The following is a description of a gene set: Genes predicted to be targets of miRBase v22 microRNA mmu_miR_758_3p in miRDB v6.0 with MirTarget v4 prediction scores > 80 (high confidence targets). species: Mus musculus from publication Chen Y, Wang X (PMID 31504780) Mouse Gene Set: MIR_758_3P, and this is the list of marker genes: Lin7a, Hepacam2, Zfhx3, Stk40, Zbtb7a, Tyro3, Tfrc, Bach2, Slc33a1, Rhou, Nopchap1, Ntn5, Ctss, Xrcc2, Pum2, Cyp7b1, Slc6a14, 9530068E07Rik, Hipk3, 2310022B05Rik, Cacng5, Eea1, Sun2, Zfp560, Inhbc, Fli1, Hnrnpu, Map2k1, Xirp2, Iws1, Gad2, Fyttd1, Trabd2b, Lrfn2, Dpp4, Zcchc9, Map7d2, Zfp503, Zfpm2, Elmo2, Eda2r, Unc5d, Gcnt1 (glucosaminyl (N-acetyl) transferase 1, core 2), Cbx2, Herc2, Trim39, Dusp11, Txndc17, Cep15, Zbtb18, Abca1, Capn12, Meis2 (Meis homeobox 2), Cnnm4, Hsd11b1, Zfp618, Fbn1, 1600012H06Rik (NCBI Gene Id 67912), Gria4, Polr3f, Nsa2, Cadm2 (NCBI Gene Id 72986), Sestd1, Rad52, Tbx4, Tube1, Hlf, Mindy3, Ino80d, Ahcy, Pak5, Prkar2b, Rnls, Gpr174, Pgrmc1, Tbxas1, Bicra, Gmeb2, Wtap, Rgs5, St7l, Col11a1, Pdzd7, Arhgef26, Cisd2, Epc1, Scn9a (NCBI Gene Id 671835), Bdp1, Zdhhc21, Tmem167, Rufy2